The following is a description of a gene set: from publication Chen Y, Wang X (PMID 31504780) studied in species Homo sapiens Genes predicted to be targets of miRBase v22 microRNA hsa-miR-153-5p in miRDB v6.0 with MirTarget v4 prediction scores > 80 (high confidence targets). Human Gene Set: MIR153_5P, and this is the list of marker genes: CCSER1, APLP2, ALK, ITGAV, RMC1, ADRA1A, OSBPL1A, METTL2A, BRDT, RBMS1, KCNC2, PHF20L1, GABRG1, ACMSD (NCBI Gene Id 130013), CTCF, NRP1, THAP1, WDTC1, AGMO, ACVR2A, TP53RK, PAK3, TMEM144, APBB2, FBXO42, PRLHR, FRMPD4 (NCBI Gene Id 9758), DYNLT5, C6orf120, SREBF1, CCDC170, PCSK5, KIAA0408, TSHZ2, PTPRJ, ZNF10, WRNIP1, BCLAF1, SEC22A (SEC22 homolog A, vesicle trafficking protein), HLF (HLF transcription factor, PAR bZIP family member), SLC7A1, PRELID2, PFN4, CCDC138, SCEL, ZC3H12C, PHF14, PIERCE2, CHIC1, PAX5, SPATA18, ARF4, TMEM170B, CLDND1, RIPOR2, MIPOL1, REDIC1 (NCBI Gene Id 283461), ADGRL3, ORC4, RALA, NME8, VAMP4, ZDHHC20, PIGM, UGT2A3, PAPPA, DEPTOR, PIK3C2B, VPS36, FZD3, RHOH, TENT5C, RAB39B, CEP63, DRD5, PCDH17, TBCK, VNN1, ESYT2 (NCBI Gene Id 57488), CCN2, LAYN, C4orf33, CD22 (CD22 molecule), LMLN, TC2N, SEMA3C, DUT, TM9SF3, KBTBD6, NOTCH1, TXNRD2, LMNTD1, THUMPD1, FEM1B, MEF2A (myocyte enhancer factor 2A), RLIM, HDAC2, PLS1, WNT3, ZEB2, HPGD, PIAS1, IRX5, EWSR1, XRN1, CBR1, NKTR, SLC9A4, FUT9, ICE2 (interactor of little elongation complex ELL subunit 2), CEP350, NTRK2, SKP2, RPS6KA5, PTPRD, LRATD2, VGLL3, RHD (NCBI Gene Id 6007), ORMDL2, AKT3, LRRN1, TMEM106B, FBXO36, SH3RF3, SLC4A7, ZIC3, C15orf32, TNFSF11, ELP4, C11orf16, ZNRF3 (NCBI Gene Id 84133), HTATSF1 (HIV-1 Tat specific factor 1), MOSPD1, SOBP, SPINK13, ZNF319, DMRTC2, SYT1, MAP3K7, TEAD1 (NCBI Gene Id 8), LIMS1, CLGN, PLPPR1, RBM41, SLC6A14, PRSS35, RBM47, CHSY1, CADM2, BIN1, USP13, ENOPH1, EPHA5, ZSCAN1, COL5A2 (NCBI Gene Id 1290), FIBIN, RGS18, CTSO, RPL34, INTS2, HIF1A, NID2, SNTB1, CALD1, CCDC102B, SELE, UBQLN2, GNAI1, PDE8A, ARFIP1 (NCBI Gene Id 27236), GRPEL1, RPAP2, DCAF10, KDM4C, SREK1, CTNNA3, NAT1, FGL2, WDR41, MOB1B, NHLRC3, CTC1, UBE4A, LMO2, PURB, ZNF33A, RNF138, CLIC6, CCSER2, SCAI, IKZF2, ITGB8, MBL2, AASDHPPT, SPDYE5, TSEN2, EREG, ARHGAP28, SNRK, DOCK8-AS1 (DOCK8 antisense RNA 1), EFCAB5, SHROOM3, CNTN4, GPHN, TRPC1, PRTG, DCP2, SLK, SMIM20, ZFR, ADGRF3, PTGFRN, CEP126, VSTM4, TNKS, CHML, TMEM41B, TMEM30A, KNDC1, UBL3, RAB30, CHCHD7 (coiled-coil-helix-coiled-coil-helix domain containing 7), ATP2C1, KLHL2, GUCY1A2, APPL2, RALBP1, LIG4, PCGF5, OBI1, LSAMP, TNRC6B, MAP3K2, OSBPL8, SKI, GNG10, GLIS3, ENTPD1, CNTNAP3B, USP49, NCEH1, KRAS, MED18, ATP13A4, HS6ST3, RIPK2, SLC5A3, TFAP2D, HOXD10, PRKRA, JADE1, PMPCB, ELAVL4, PRKAA2 (NCBI Gene Id 5563), SLITRK4, MITF, KLHDC10, UBE2K, MSL2, ACER3, SESN3, SPDYE6, PAQR5, RBMS3, SLC9A8, EIF4B, MDM4, USP46, RP1, RFX6, PRXL2C, KCTD3, PROX1, RIMKLB, RBMS2, ZNF506, ZBTB7A, CDC73, FAT3, PPFIA2, USF3, SOX6, MEST, FANCD2OS, LSM11, ARHGAP32, GPCPD1, MTREX (Mtr4 exosome RNA helicase), PHIP, ADGRL4, DLAT, TASL, CERKL, COBLL1, WBP2, RORB, PGRMC1, TLE4, ARL13B, PELI1, DENND4C, UROS, NOTUM, SYCP2, DIAPH3, PEX13, BEND6, LPL, ARRDC4, SGIP1, TMEM167A, PTPN4, UBE2A, CPEB3, KLHL41, ZNF81, LIN9, ATP1A2, LRATD1, SLC16A7, SAMD8, ARPC5, MFSD6, PYGO2, NMD3, LRRC4C, PCSK2, TMEM168, AEBP2, KCTD6, CCNT1, IBSP, SLC1A3, TMEM87B, DDHD2, ADAMTS3 (ADAM metallopeptidase with thrombospondin type 1 motif 3), CSN2, CANX, PRKAB2, ZNF566, RAB8B (RAB8B, member RAS oncogene family), MTDH, AHDC1, PIN4, NFYB, CDC37L1, ZNF800, SEMA5A, TMEM33, LDB1, AKAP5, GPR146, PLG, GTF2H5, SLC22A15, CNTLN, NDFIP2, TMCO1, CXCL8, CBX5, SEC23IP, NEXMIF, DCP1A, MFAP3L, EMSY, OMD, PABPC3, PGAP1, DSE, NDST3, NCKAP5 (NCK associated protein 5), SENP6, GABPA, ZHX3, STAG2, SPOPL, KCTD8, IFNAR1, ARHGAP42, EMX2, TRGC1, FGD6, SRGAP2C, STEAP4, PKDCC, C1orf43, CERS6, PCDH9, CAPS2, MARK1, OTUD6A, ARMC8, MTCL3, SLC35E3, ATP1B4 (ATPase Na+/K+ transporting family member beta 4), NMNAT2, MTARC1, ZNF107, BNIP3L, GABRA5, ANKRD44 (NCBI Gene Id 91526), BMP3, PHF6, MIGA1, ENY2, SP3, FAM72A, CXCR6, RPS6KA3, MYO5C, PDZD2 (PDZ domain containing 2), CHUK, USP10, FGF12, FRS2, CLVS2, USP38, SERINC1, TLN1, SDHC, NUTM1, PDCL, SNX2, ABCE1 (NCBI Gene Id 6059), DDX39B, INSYN2A (NCBI Gene Id 650000), OFD1, HMGCLL1, SEH1L, EXOSC8, GRK5, MCTP2, CCDC43, SGCD, TMF1, RPP38-DT, RELL1 (NCBI Gene Id 768211), TOR1AIP2, PTGR3, NR3C2, RFESD, NEDD1, CHRNA9, MDGA2, FCHO2, TBC1D4, CCDC71L, PUM2, MYSM1, TAF4B, PLGLB2, TRIP11, GABRB2, TAOK3, ADSS1, STK4, YY2, USP22, RAB33B, SGMS1, RASSF8 (NCBI Gene Id 11228), SLIT3, ERCC6L2, GPATCH2L, SLC10A2, KPNA4, ARNT2, ZNF652, ZNF565, ATE1, UBR5, PLEKHJ1, SPOCK3, PIGA, DEPDC1B, AP1B1, ZNF563, FBXL3, CNIH1, TMED5, WT1, ABHD2, OXR1, KLHL5, CLEC2D (NCBI Gene Id 29121), SEMA3A, CELF2, SART1, TMEM135, KCNB2, RRM2B, PLGLB1, TVP23A, COL19A1, DENND6A, MSRB3, PTCHD1, FAM168B, LNX1, NR1D2, CHODL, ALG6, NAAA, RUNX1T1, SLC4A10 (solute carrier family 4 member 10), DIRAS3, LRRTM2, RPS6KB1, AUH, ERI2, FAM169A, ZNF124, AOC2, WDR72, RPAIN, SLCO1B3, DGKE, NSD2, PRG4, ENTPD6, FOXP2, KCNJ3, LRP1, RIC1, DMRT1, PPP1R9A, SAXO2, ALDH2, N4BP2, CNTN5, RXFP1, ZC3H11A (zinc finger CCCH-type containing 11A), FAM72D, SHPRH (NCBI Gene Id 282561), PTPN3, NEK7, FAM120A, BCAT1, CD59, GHR, C2orf80, PPP2R5E, TSN, TTC31, ZCCHC2, HOXA13, FAM72B (NCBI Gene Id 653820), NECAP1, DNAJC12, TLCD4, SRGAP2B, GPC5 (glypican 5), AUTS2, SLC36A4, TTC7B, ARHGAP24, ATXN1, STX3, SYNPO2, LCOR, ALDOB, KGD4, ZNF267, CDKN2AIP, ERICH2, CLHC1 (clathrin heavy chain linker domain containing 1), C17orf75, DACH2, NLGN4Y, YTHDF3, FAM210B, AGPS, DENND5B, CLDN8, ZNF503, SLC25A17 (solute carrier family 25 member 17), RBAK, PRR27, NPEPPS, PCMTD1, MIER1, IGSF10, OMA1, OTUD1, MS4A14, TEP1, CYP2C18, DPH6, HPCAL4, LAP3, MMP16, PLEKHA1, ATXN3, CAMTA1 (calmodulin binding transcription activator 1), ATG14, STRN3, IGFBP7, IFIT5, ATXN7, TNRC6A, CTTNBP2NL, DAZL, C8orf88, TIA1, PSMD5, CNTNAP2, FOXG1, TGFBR1, MYOCD, GEMIN8, PDCD4, ACOD1, EBF2, PLPBP (NCBI Gene Id 11212), FIGN, RBPJ, ZNF197, TOX3, EEA1, CDKL1, ARMC10, SPMIP4, ZNF780A, TMEM263, PPP4R2, DKC1, MCM8, TATDN3, SLC25A24, LRP12, TTC8, PDE11A, SQLE, SLC24A2, HOOK3, DDX60, NLGN1, SLC4A4, COPS2, LRRTM3, NALCN, NEGR1, CWC22, CALM1, SDR42E1, SLC24A4 (solute carrier family 24 member 4), PTPRG, CHL1, SLAIN2, MPPED2 (NCBI Gene Id 744), KLHL32, ACBD5, CEP135, ZNF670, SIX4, CILK1, TRDN, TCEANC2, PDCD6IP, AGA, ZNF326, ELOVL2, CISD2, LTN1, TOB1, A1CF, ZRANB3, S100A14, PNN, WNT9B, CADPS, OMG, ID4, RELN, KIF5B, VAPA, PREX2, SLC7A3, OR11A1, CNDP1, DGKI, ZNF277, QKI, ARID2, L2HGDH, PGM2L1, CCSAP, SLC17A6, TDRD7, ATMIN, BACH1, AFF2, KAT6A, CLINT1, DYNC2LI1, SNX25 (sorting nexin 25), PDE1C, TRIM33, TMEFF1, CSRNP3, CHD6, MTCH2, DICER1, EXD2, EPHA3, WAPL (WAPL cohesin release factor), STXBP5, CHD1, GATAD1, ZFP36L1, TMEM236, LMO4, RBMXL1, CAV2, TMEM233, CD24, PELATON, SELENOF, GCA, KLHL28, TUT7, CUL5, TSPAN7, ITK, SLC38A2, LEMD3, CHMP2B, CREBZF, POLR2M, CREB1, ADAM19, WNT16, DNTTIP2, KRTAP5-11, CPSF6, PPM1L, RBM39, KHDRBS2, OTUD6B, PCDH11Y, SRSF10, GRIK2, RASSF6, ITGBL1, SKIL, NEMF, IRAK3, SPAST, OTUD7B, CLEC19A, MPDZ, RAN, RMND5A, VPS29 (NCBI Gene Id 51699), RAB27B, CXCL10, ATG16L2, IL6R, NHS (NHS actin remodeling regulator), IGIP, ZNF536, PPP4C, TSHZ1, APOOL, FOXF1, MTPAP, TMPO, ADK, CYP2U1, TARP, MEF2C, ZBTB33, FAHD1, RBMX, ZNF568, DDX6, INO80D, TMEM74, B3GNT5, SLC49A4, LZTFL1, COMMD8, MGAT4A, ZMPSTE24, NCOA5, FOXL1, VRK3, ZNF229, SAMD12, ABI2, KLF8, PYGO1, LPCAT2, PIGC, NKAIN2, THSD7A, NEUROD1, EHHADH, LRAT, ALG13, C2orf69, CCDC186, RAB11FIP2, LILRB4, CWC27, LSM8, CNGA1, PLPPR4, C8orf34, KLK7, MORC1, SPON1, COL2A1, ATG5, ERBB4, STON2, GPBP1, CDK2, NCK1, KCNQ3, C5orf63, SMAD5, EFNB1, TMEM260, ZFHX3, GABRA4, NEDD9, CXXC5, FBXO11, UST, OSBPL3, FHL1, SNAP29, GOLIM4, TENT2, ANO5, AGFG1, SMIM15, RAB9B, IMMP2L, LRRK2, DNAJC19, ACSL6, KLHL24, BDP1, PPP2R1B, PEAK1, EPC1, GTPBP2, NKAIN3, SH3TC2, NUDT11, SLC16A1, OSBPL9, CNTNAP3, CUL4B (NCBI Gene Id 8450), TOMM22, ZFP28, ANKRD50, GPR34 (NCBI Gene Id 2857), PPP3CA, GLS, PHYHIPL (NCBI Gene Id 84457), FAM171A1, CBFB, DCK, MTX3, NUS1, PGR, CDK6, EIF4E3, TAOK1, SLITRK1, TNFRSF21, PRDM16, MAP4K4, MAP3K20, MYO6, SMC6, NFIC, RFX3, HYCC2, CYBB, MAP2, PDS5A, TMTC1, PRPF39, MYOG, CCNT2, TFB1M, OSBP2, EPCIP, PBX1, HS3ST5, C5AR1, DHX33 (NCBI Gene Id 56919), C1QTNF7, APH1B, DOCK5, ATP8A1, MARCHF1 (membrane associated ring-CH-type finger 1), USH2A, NETO1, RNF11, PABPC5, ARG1, MAGI3, THAP2, C2CD5, SLC5A12, RHOQ, DGKH, GPATCH8 (NCBI Gene Id 23131), STK26, CCDC180, TFDP2, ADAM9, PCMT1, ANOS1, USP51, TASOR, AMD1, MAPKAP1, DCDC2, MRPS35, AP3S1, SRRM2, IPO7, MBTD1, GPX7, FAM210A, SAXO1, LRCH2, MBNL3, CROT, USP3, PIKFYVE, LPCAT4, RCC2, PRSS55, KCNMA1, RABGAP1L, CCDC50, GNAI2, MTMR7, CRISPLD2, NEDD4L, ZNF367, CYRIA (NCBI Gene Id 81553), KIAA1549L, CEBPG, CHRAC1, MMS22L, PDE12, RSPO3, WNK3, LRP6, PDIK1L, VAPB, DUSP19, RBM25, MON2, NPY1R, UQCR11, BICC1, HMBOX1, ARID4A, PLXDC2, LRRCC1, ELL2 (elongation factor for RNA polymerase II 2), ZCWPW2, NOL11, CLOCK, SLC15A5, CLDN2, CSGALNACT1, RAD51B, TRIM2, ZNF384, YY1, ANXA1, SERBP1, TBCEL, C12orf50, IBTK, CDKN1B, ONECUT2, ZNF75D, SP5 (Sp5 transcription factor), UBA5, GABRG2, ACSL3, POGZ, ARID1A, KBTBD3, ZNF512, JMY (NCBI Gene Id 23651), NECTIN1, ZBTB41, IGF2BP2, CBLL1, RAB11A, CCDC28A-AS1, AAK1, DPY19L1, FRYL, TMED7-TICAM2, MED13L, IL12B, ERICH5, SYT11, PTBP3, LARP1, NOTCH2NLA, SH3GLB1, CDKN2A, TMEM68, M6PR, ZSCAN12, AIRIM, HDAC9, AGO1, ETF1, TMEM229A, OTOA, TBC1D31 (TBC1 domain family member 31), CREB5, ZNF22 (NCBI Gene Id 7570), ATL3, VTA1, PERP, ROBO1, POU2F1, NDFIP1, FRK, ACOT13, TENM4, PPP4R3B, FMN1, EGFL7, DACH1, EP300, ARHGAP1, PTPRB, SLC6A6, KLF4, PDC, HSH2D, PLEKHH2, MYRIP, PCMTD2, ATP8B1, NUDT4, GRM5, PNPLA8, GAS2, TXLNB, DCUN1D4, FANCD2, CAMK4, TAB3, IPO5 (importin 5), CFAP57, FGFR2, SLC13A1, NMI, ACVR1C, TICAM2, GNAL, BTG2, MET